The following is a description of a gene set: Human Gene Set: HP_PANCREATIC_FIBROSIS Pancreatic fibrosis species: Homo sapiens, and this is the list of marker genes: TCTN2, RPGRIP1L, DYNC2I1, TCTN3, PTRH2, B9D1, NEK1, TMEM216, TXNDC15, CC2D2A, B9D2, MKS1, CSPP1, RPGRIP1, SLC37A4, NPHP3, TMEM67, TCTN1, TMEM231, TMEM237, CEP290, TMEM107